The following is a description of a gene set: from publication Xu XQ, Emerald BS, Goh EL, Kannan N, Miller LD, Gluckman PD, Liu ET, Lobie PE (PMID 15845533) We have exploited a discrepancy in the oncogenic potential of autocrine and exogenous human growth hormone (hGH) in an attempt to identify molecules that could potentially be involved in oncogenic transformation of the human mammary epithelial cell. Microarray analysis of 19,000 human genes identified a subset of genes in a human mammary carcinoma cell line that were remarkably different in their response to autocrine and exogenous hGH. Autocrine and exogenous hGH also regulated 167 common genes. Semiquantitative reverse transcription-PCR confirmed differential regulation of genes by either autocrine or exogenous hGH. Functional analysis of one of the identified autocrine hGH-regulated genes, TFF3, determined that its expression is sufficient to support anchorage-independent growth of human mammary carcinoma cells. Small interfering RNA-mediated knockdown of TFF3 concordantly abrogated anchorage-independent growth of mammary carcinoma cells and abrogated the ability of autocrine hGH to stimulate oncogenic transformation of immortalized human mammary epithelial cells. Further functional characterization of the identified subset of specifically autocrine hGH regulated genes will delineate additional novel oncogenes for the human mammary epithelial cell. studied in species Homo sapiens Human Gene Set: XU_GH1_EXOGENOUS_TARGETS_DN Genes down-regulated in MFCF-7 cells (breast cancer) by exogenous HG1., and this is the list of marker genes: SPRY2 (NCBI Gene Id 10253), TFDP3, CYP4F3, CFAP107 (cilia and flagella associated protein 107), MED12L, ELAVL4, PPP1R3A, NRTN, ZNF473, PHOX2B, GAD2, APOM, APOBEC2, ERCC4, SCGB2A1, DBF4, GLRX, GBX2, PIK3C2A, SLC23A1, FANCM, FOXO4, ITGB3, PLG, KCNAB2, HS3ST1, SNAP91, RFPL1, NDUFB9, TFEC, MITF, FAM135A, PDCD1LG2 (programmed cell death 1 ligand 2), LUZP4, RNF144A, SYNPO2, GPR171 (NCBI Gene Id 29909), TMC6, MUC3A, OAS2, NDUFS3, OXCT2, GPLD1, PYGM, CES3, PLCXD1, BMP8B, MAN1C1, ZFP2, ZNF616, SP4, MINDY2, CACNA1C, TCP1, DNAJC1, ZNF19, PURG, HPSE, CES2, USP2, CA6, PMCH, BMP2, GALNT9, ESRRG, CARD18, SNAI2, ECPAS, INTS6, SLC23A2, UBXN8, PFKFB4, SMARCA1, ADPRH, TANGO6, SLC12A1, CPS1, CYB5A, SLC4A7, HMGB2, CPB1, LBX1 (NCBI Gene Id 10660), C6orf15, ZNF419, CDC14A, CBX1, SGK1 (serum/glucocorticoid regulated kinase 1), H2BC12, PRDX3, SLC2A8, PPP1R2C, TAF2, NOX3, PPEF2, SOX1, RASGRF2, SLC35B3, METTL5, NACAD, ACADL, WFS1, GPR180, ARSF (NCBI Gene Id 416), ZNF654, CEP192